The following is a description of a gene set: Human Gene Set: RAGHAVACHARI_PLATELET_SPECIFIC_GENES Genes in this set correspond to the most abuntant transcripts that are also specific to platelets. studied in species Homo sapiens BACKGROUND: In sickle cell disease, ischemia-reperfusion injury and intravascular hemolysis produce endothelial dysfunction and vasculopathy characterized by reduced nitric oxide and arginine bioavailability. Recent functional studies of platelets in patients with sickle cell disease reveal a basally activated state, which suggests that pathological platelet activation may contribute to sickle cell disease vasculopathy. METHODS AND RESULTS: Studies were therefore undertaken to examine transcriptional signaling pathways in platelets that may be dysregulated in sickle cell disease. We demonstrate and validate in the present study the feasibility of comparative platelet transcriptome studies on clinical samples from single donors by the application of RNA amplification followed by microarray-based analysis of 54,000 probe sets. Data mining an existing microarray database, we identified 220 highly abundant genes in platelets and a subset of 72 relatively platelet-specific genes, defined by >10-fold increased expression compared with the median of other cell types in the database with amplified transcripts. The highly abundant platelet transcripts found in the present study included 82% or 70% of platelet-abundant genes identified in 2 previous gene expression studies on nonamplified mRNA from pooled or apheresis samples, respectively. On comparing the platelet gene expression profiles in 18 patients with sickle cell disease in steady state to those of 12 black control subjects, at a 3-fold cutoff and 5% false-discovery rate, we identified approximately 100 differentially expressed genes, including multiple genes involved in arginine metabolism and redox homeostasis. Further characterization of these pathways with real-time polymerase chain reaction and biochemical assays revealed increased arginase II expression and activity and decreased platelet polyamine levels. CONCLUSIONS: The present studies suggest a potential pathogenic role for platelet arginase and altered arginine and polyamine metabolism in sickle cell disease and provide a novel framework for the study of disease-specific platelet biology. from publication Raghavachari N, Xu X, Harris A, Villagra J, Logun C, Barb J, Solomon MA, Suffredini AF, Danner RL, Kato G, Munson PJ, Morris SM Jr, Gladwin MT (PMID 17353439), and this is the list of marker genes: HBA1, TUBA4A, PTPN12, RSU1, PF4, PF4V1, RGS10, PRUNE1, ODC1, LEPROT, PIP4K2A, CXCL5, H2BC21, NRGN, HBG1, GNAS, CTSA, EIF2AK1, RNF11, TPM1, ITGB3, H2BC12, NAP1L1, PRKCB, APP, VCL, BEX3, MYLK, TSC22D1, SPARC, MAP3K7CL, H2AC6, MAX, TMEM140, MMD, CCL5, GLA, TNFSF4, DAPP1, THBS1, CTTN (NCBI Gene Id 2017), PRKAR2B, SNCA, ITGB5, ASAH1, MFAP3L, F13A1, PTGS1 (prostaglandin-endoperoxide synthase 1), GNG11, H3C10, PRDX6, SNN, MPP1, KIF2A, YPEL5, RAB31, TUBB2A, TAX1BP3, PPBP, RUFY1, FHL1, ZNF185, ENDOD1, RYBP, ITGA2B, MLH3, PGRMC1, PPM1A, WIPF1, RABGAP1L, PDLIM1, HBB